Given this list of marker genes EP300, PSMA3, PSMC3, PSMC1, PSMD8, TGFB1, SMURF2, PSMD13, UBB, CBFB, RPS27A, PSMD12, SEM1, PSMB4, SRC, PSMB1, PSMA5, PSMC5, PSMC4, PSMB5, PSMD7, ADRM1, UBA52, PSMA4, RUNX3, PSMC6, PSMA2, PSMB7, PSMC2, PSMD2, PSMA1, UBC, PSMB2, PSMA6, CDKN2A, PSMD1, PSMD11, SMURF1, PSMB6, PSMD6, MDM2, PSMD14, PSMA7, PSMD3, PSMB3, here is a description of the gene set: Human Gene Set: REACTOME_REGULATION_OF_RUNX3_EXPRESSION_AND_ACTIVITY Regulation of RUNX3 expression and activity species: Homo sapiens